The following is a description of a gene set: Neoplasm of the respiratory system Human Gene Set: HP_NEOPLASM_OF_THE_RESPIRATORY_SYSTEM species: Homo sapiens A tumor (abnormal growth of tissue) of the respiratory system., and this is the list of marker genes: SFTPA2, DICER1, MBTPS2, GPC3, EGFR, IFNG, BRCA2, EPCAM, DIS3L2, NSD1 (NCBI Gene Id 6797), COL4A5 (collagen type IV alpha 5 chain), STAT6, COL4A6, AKT1, RSPO1, MAP3K8, POU6F2, WRN, RB1, WT1, NLRP1, AAGAB, EWSR1 (EWS RNA binding protein 1), TRIM28, REST, KEAP1, LMNA, NAB2, HPGD, PRKAR1A, STK11, PMS2, CYP2A6, H19, CAT, NDUFAF6, BAP1, ERBB2, MSH6, KRAS, CHEK2, BRAF, PDGFRB, TSC1, TP53, MSH2, MDM2, PIK3CA, FASLG, PMS1, ERCC6, PORCN, TRIP13, MUC5B (NCBI Gene Id 727897), MST1R, IRF1, APC2, SLCO2A1, TSC2, PDE11A, TERT, NOTCH3, SFTPC, TGFBR2, COL14A1, MLH1, CASP8, PRKN, ZFTA, TRPV3, PERP, SPRED1, SLC22A18 (solute carrier family 22 member 18), CDKN2A, ZNRF3, CTNNB1, PPP2R1B